Given this list of marker genes Gm5735, Gm3200, Gm10602, Pgap2, Chrdl2, Gm7027, Plekhb1, Il18bp, Xrra1, Gm18959, Gm10603, Gm17931, Art5, Inppl1, Tomt, Mrpl48, Lrrc51, Folr2, Fchsd2, Lipt2, Pgm2l1, Rnf121, Gm8463, Numa1, Gm47324, Kcne3, Mir139, Chrna10, Ucp2, Gm35363, Art2a, Rhog, Trpc2, Dnajb13, Rnf169, Ppme1, Atg16l2, Phox2a, Spcs2, Folr1, Gm14382, Stim1, Pold3 (NCBI Gene Id 97395), Gm7067, Fam168a, Gm35082 (NCBI Gene Id 102638545), P4ha3, Stard10, Xntrpc, Rab6a, Gm8523, Arhgef17, Relt, Ucp3, Lamtor1, Art2b, Gm45620, A930030B08Rik, Gm38405, Gpx2-ps1, P2ry2, Gm6341, Art1, Nup98, Pde2a, Mir3102 (NCBI Gene Id 100526508), C2cd3, Anapc15, Gm39059, Coa4, Xndc1, Clpb, Gm34821, Cox20b, P2ry6, Arap1, here is a description of the gene set: Mouse Gene Set: chr7E2 species: Mus musculus